Given this list of marker genes Mertk, Ccr2, Anxa1 (annexin A1), Hmgb1, Axl, Xkr8, here is a description of the gene set: species: Mus musculus The selective elimination of senescent neutrophils from the body by autoregulatory mechanisms. Mouse Gene Set: GOBP_NEUTROPHIL_CLEARANCE